Given this list of marker genes bfr, irtA, LTF, bfrB, Rv2895c, irtB, here is a description of the gene set: Reactome Pathway: Mtb iron assimilation by chelation part of: Latent infection - Other responses of Mtb to phagocytosis species: Homo sapiens Uptake of iron in <i>Mtb</i>, especially when the bacterium is in the host, strongly depends on siderophores. Humans, through secretion of lactoferrin, maintain an iron concentration of 10^(-18) M within macrophages, and the bacterium has evolved the siderophores mycobactin T and exomycobactin T (formerly exochelin) to cope with this shortage. While nonpolar mycobactin T stays in the cell wall and only moves around in liquid droplets, polar exochelin is abundantly secreted. As it can bind iron with higher affinity than lactoferrin, it frequently scavenges iron ions from this molecule (Miethke & Marahiel 2007).